Given this list of marker genes MPO, RUNX1, CSF1R, IL3, CSF2, here is a description of the gene set: Pathway Definition from KEGG: RUNX1* // (CSF1R,MPO,CSF2,IL3) studied in species Homo sapiens Mutation-inactivated RUNX1 to transcription. Pathway ID: N00116. Pathway type: Variant. Pathway class: nt06275 Acute myeloid leukemia. Human Gene Set: KEGG_MEDICUS_VARIANT_MUTATION_INACTIVATED_RUNX1_TO_TRANSCRIPTION